The following is a description of a gene set: The chemical reactions and pathways resulting in the formation of any purine nucleoside, one of a family of organic molecules consisting of a purine base covalently bonded to a sugar ribose (a ribonucleoside) or deoxyribose (a deoxyribonucleoside). studied in species Homo sapiens Human Gene Set: GOBP_PURINE_NUCLEOSIDE_BIOSYNTHETIC_PROCESS, and this is the list of marker genes: NT5E, MAPDA, ADA, APRT, ADA2, PRTFDC1, PNP, PGM2, ADK, HPRT1, MTAP